The following is a description of a gene set: Human Gene Set: HP_SQUAMOUS_CELL_CARCINOMA_OF_THE_SKIN Squamous cell carcinoma of the skin studied in species Homo sapiens Squamous cell carcinoma of the skin is a malignant tumor of squamous epithelium., and this is the list of marker genes: XPC, ERCC5, LMNA, NAF1, IL7, STAT4, OCA2, TERT, DDB2, TYR, KRT14, RSPO1, SMARCAD1, TINF2, TYMS, TERC, ERCC3, MC1R (NCBI Gene Id 4157), XPA, ERCC4, KRT5, TMC8, ERCC2